Given this list of marker genes WWC1, HES1, PBX1, MAMLD1, HEY1, KAT2A, MAML1, PTCRA, NOTCH1, KAT2B, STAT1, SNW1, MAML3, HEY2, MAML2, HEYL, RBPJ, CREBBP, NOTCH3, HES5, PLXND1, DLGAP5, FABP7, IKZF1, EP300, here is a description of the gene set: In the nucleus, NICD3 forms a complex with RBPJ (CBF1, CSL) and MAML (mastermind) proteins MAML1, MAML2 or MAML3 (possibly also MAMLD1). NICD3:RBPJ:MAML complex, also known as the NOTCH3 coactivator complex, activates transcription from RBPJ-binding promoter elements. While NOTCH1 prefers paired RBPJ binding sites, NOTCH3 preferentially binds to single RBPJ binding sites.<p><p><br>NOTCH3 coactivator complex induces transcription of the well established NOTCH target genes HES1, HEYL, HES5 (Lin te al. 2002, Shimizu et al. 2002), and HEY2.<p><p>NOTCH3 positively regulates transcription of the pre-T-cell receptor alpha chain (PTCRA, commonly known as pT-alpha or pre-TCRalpha). IK1, splicing isoform of the transcription factor Ikaros (IKZF1), competes with RBPJ for binding to the PTCRA promoter and inhibits PTCRA transcription. NOTCH3, through pre-TCR signaling, stimulates expression of the RNA binding protein HuD, which promotes splicing of IKZF1 into dominant negative isoforms. These dominant negative isoforms of IKZF1 heterodimerize with IK1, preventing its binding to target DNA sequences and thus contributing to sustained transcription of PTCRA.<p><p>NOTCH3-triggered pre-TCR-signaling downregulates the activity of the transcription factor TCF3 (E2A), through ERK-dependent induction of ID1. Inhibition of TCF3-mediated transcription downstream of NOTCH3 contributes to development of T-cell lymphomas in transgenic mice expressing NICD3. Activation of ERKs downstream of NOTCH3-stimulated pre-TCR signaling leads to phosphorylation of the transcription factor TAL1, formation of the TAL1:SP1 complex, and activation of cyclin D1 (CCND1) transcription, which stimulates cell division.<p>NOTCH3 signaling can activate NF-kappaB (NFKB)-mediate transcription either indirectly, through activation of pre-TCR signaling, or directly, through association of NOTCH3 with IKKA. NFKB is constitutively active in T lymphoma cells derived from NOTCH3 transgenic mice.<p><p>Transcription of the PLXND1 gene, encoding the semaphorin receptor Plexin D1, is directly stimulated by NOTCH1 and NOTCH3 coactivator complexes. PLXND1 is involved in neuronal migration and cancer cell invasiveness. Expression of FABP7 (BLBP) in radial glia is positively regulated by NOTCH1 and NOTCH3 during neuronal migration.<p><p><br>NOTCH3 gene is frequently amplified in ovarian cancer. NOTCH3 coactivator complex directly stimulates DLGAP5 transcription. DLGAP5 is involved in G2/M transition and is overexpressed in ovarian cancer cells.. Another gene overexpressed in ovarian cancer whose transcription is directly stimulated by NOTCH3 is PBX1. The NOTCH3 coactivator complex directly stimulates WWC1 gene transcription. WWC1 gene encodes protein Kibra, involved in Hippo signaling. NOTCH3-mediated induction of WWC1 positively regulates Hippo signaling and inhibits epithelial-to-mesenchymal transition (EMT) in triple negative breast cancer cells.<br> Reactome Pathway: NOTCH3 Intracellular Domain Regulates Transcription species: Homo sapiens part of: Signaling by NOTCH3